The following is a description of a gene set: Mouse Gene Set: GOBP_REGULATION_OF_BARBED_END_ACTIN_FILAMENT_CAPPING species: Mus musculus Any process that modulates the frequency, rate or extent of barbed-end actin filament capping., and this is the list of marker genes: Carmil1, Mtpn, Arpc2, Cfl1, Carmil2, Cracd